The following is a description of a gene set: Reactome Pathway: IRF3 mediated activation of type 1 IFN electronically inferred by orthology from the curated human pathway studied in species Mus musculus part of: ZBP1(DAI) mediated induction of type I IFNs This event has been computationally inferred from an event that has been demonstrated in another species.<p>The inference is based on the homology mapping from PANTHER. Briefly, reactions for which all involved PhysicalEntities (in input, output and catalyst) have a mapped orthologue/paralogue (for complexes at least 75% of components must have a mapping) are inferred to the other species., and this is the list of marker genes: Irf3